The following is a description of a gene set: Mouse Gene Set: GOBP_REGULATION_OF_ISOTYPE_SWITCHING studied in species Mus musculus Any process that modulates the frequency, rate or extent of isotype switching., and this is the list of marker genes: Stat6, Atad5, Kmt5c, Mad2l2, BC037156, Supt6, Paxip1, Shld3, Rif1, Trp53bp1, Msh2, Ptprc, Mir181b-1, Tnfsf13, Cd40, Nsd2, Kmt5b, Clcf1, Ifng, Mlh1, Exosc3, Tgfb1, Tbx21, Slc15a4, Tfrc, Pms2, Ndfip1, Shld2, Tnfsf4, Exosc6, Parp3, Aplf, Il2, Il4, Bcl6, Shld1, Cd28, Pagr1a, Il27ra, Hmces, Mir181b-2, Foxp3